The following is a description of a gene set: Human Gene Set: AIZARANI_LIVER_C6_KUPFFER_CELLS_2 from publication Aizarani N, Saviano A, Sagar, Mailly L, Durand S, Herman JS, Pessaux P, Baumert TF, Grün D (PMID 31292543) studied in species Homo sapiens, and this is the list of marker genes: SAMHD1, BCAT1, FMNL2, HK3, THEMIS2, MFSD1, MARCHF1, CFD, RGS2, FYB1, IFNGR2, GPNMB, CCL4L2, FTL, GRN, SLC15A3, GRB2, LILRB1, CYBA, SCARNA9, SLC40A1, MARCO, HLA-DPB1, AIF1, CFP, ZEB2, TNFSF13B, CCDC88A, CXCL16, LAPTM5, FCGBP, CTSB, TLR2, PLXDC2, CREG1, IFI6, POU2F2, HLA-DMB, SLA (Src like adaptor), SLC7A7, IL1B, C5AR1, CNTRL (NCBI Gene Id 11064), RASSF4 (Ras association domain family member 4), NPC2, MS4A7, PLTP, VAMP8, NAGK, C3AR1, MSR1, C1QA, MAF, HLA-DRA, RNASE1, SCIMP, CTSD, HLA-DPA1, CYFIP1, HCLS1, GPR34, SLCO2B1, PSAP, LGALS9, CD14, TNFRSF1B, CD5L, ARPC1B, LGMN, WASF2, IFI44L, RNASE6, VSIG4, C1orf162, CYBB, GLUL, CEBPB, STX7, ATP6AP1, CTSS (cathepsin S), FCN1, TKT, MAFB, F13A1, TBXAS1, LYVE1, FRMD4A, ARRB2, ATP2B1-AS1, CD163, PLEK, ITGB2, MRC1, OGFRL1, FOLR2, TTYH3, SRGAP1, AP1B1, RHOG, FTH1, IFIT3, RBPJ, SNX10, MS4A4A, FCGRT, IER3, SLC31A2, MTSS1 (MTSS I-BAR domain containing 1), ADAP2, VSIR, LIPA, CALHM6, PLD3, PYCARD, LILRB5, HLA-DRB1, IRAK3, SECTM1, CLEC7A, RBM47, SRGAP2B, FRMD4B, TYMP (thymidine phosphorylase), SLC11A1, HMOX1, CD86, OAS1, EPB41L2, ALOX5, SAT1, GNAI2, SKAP2, LIMS1, BASP1, COLGALT1, TPP1, CXCL12, P2RY13, IL18, FGR, RAP2B, CSF1R, SDCBP, EVI2B, ATP6V1B2, WSB1, TYROBP, ITGAX, LILRB2, KCTD12, MGAT1, GPX1, CPVL, ACTB, PELATON, CLN8, CCR1, RGS1, MPEG1, FCER1G, PDK4, VCAM1, TMSB10, CNPY3, MARCKS, MACROH2A1, MPP1, AP2A2, HLA-DMA, ITSN1, CST3, SGK1, EPB41L3, PILRA, UNC93B1, MERTK, FILIP1L, FCGR2A, IGSF6, UCP2, SPI1, LST1, CPM, TGFBI (transforming growth factor beta induced), C1QB, COTL1, PPT1, PTAFR, FCGR3A, ASAH1, DAB2, LAIR1, CD83, CTSC, TNFAIP2, GRINA, CD4, CCL4, S100A11, LILRB4, MS4A6A, SCAMP2, LYN, TCIRG1, C1QC, LILRB3, SDC3, ADA2, GRK2, LRRC25, FGD2, CCL3L3, RNASET2, RAB31, AXL, FGL2, KLF4, LYZ, BLVRB, HLA-DQA1, RGL1, SLC1A3, RNF144B, CD84, HCK, PTEN, ZFHX3, NCKAP1L